Given this list of marker genes G6PC3, NUTF2, USP8, LAPTM4B, ITPR1, DPAGT1, CRIP1, IAH1, EXTL3, OAT, MAGOHB, GKAP1, TMBIM1 (NCBI Gene Id 64114), MACIR, TAX1BP3, PPP2R3C, C18orf54, RCAN1, DPY19L4, ZC3H12C, IFT52, SUPT3H, HMGA1, IQGAP3, RAB11A (NCBI Gene Id 8766), PRELID3B, TUBB2A, CENPE, TOR3A, DBI, AVPI1, AKT1, BRIP1, ARHGDIA, SLC25A11, ARHGAP26, TMEM107, PGLS (6-phosphogluconolactonase), PGAP6, HK3, VAMP8, VPS35, DNAJB14, B4GALT4 (NCBI Gene Id 8702), PREP, CTNNBIP1, ANP32E, SUMF1 (sulfatase modifying factor 1), GNB2, IMPA2, QSER1, NAGPA, KPNA3, LANCL2, COP1, SLC25A24, RNF130, DOCK7, GCA, LSR, MAP4K1, NIPA2, MAP2K4, MCUB, CD38, BCL2L14, MAPKAPK2, CTDNEP1, SLC25A39, SOCS5, RANBP1, NFKB2, LTBR, SNX10 (sorting nexin 10), HPSE (NCBI Gene Id 10855), WDR11, TUFT1, MOB1A, E2F1, MOB3B, CCNA2, ELOA, PTPN9, LPCAT1, BID, WDR41, CBR3, SPAG9, DLGAP5, DUT, KIF5A, STT3A, ANXA7, SIGMAR1, FCER1G, NEDD8, EVI2B, GAS2L3, HINT1, ILDR1, RNF135, NCKAP1L, IFNAR2, MX2, MFSD12, TLR2, ATP6V0E1, MMS22L, TGFB1, SEPSECS, PLEKHO2, CSGALNACT2, PMF1, ELMO2, PALLD, ATAD2, LAP3, SNRPD1 (NCBI Gene Id 6632), CCDC28B, TSPAN31, RRAGC, SLC35E3, MED9, XBP1, DCLRE1A, MIS18BP1, CAPZA2, DEK, PLK4, CDC45, RCN2, SSR3, MTHFS, CALR, NRM, CYB5R4, LITAF, HIPK2, C4orf19, SERPINB9 (NCBI Gene Id 5272), UGGT1, AURKA, EID1, MTCH1, UMAD1, PLEKHG3, IL13RA1, SKP2, RPS27L, MYO18A, KIF23, SH3BGRL3, DSN1, TMTC3, UBE2E3, CCDC88A, NDST2, SOX12, KIFAP3, MAN1C1, FANCL (NCBI Gene Id 55120), NDC1, TEP1, SH2B3, STX12, TAOK2, TMED3, LIX1L, SNRPA1, CENPS, FNBP1L, MATK, RCC1 (NCBI Gene Id 751867), G3BP1, IL4I1, CASP7, ALMS1, PNPO, YWHAG, TM2D2, GAMT, SEMA4C, NOTCH2, TRIT1, PPT2, AKAP1, GLCE, PDIA3, EEFSEC, RFC4, SLC25A4, PALB2, GCNT1, PSEN1, IPO5, ALS2, POLR1H, CENPI, M6PR, MST1, here is a description of the gene set: species: Homo sapiens from publication Suryani S, Fulcher DA, Santner-Nanan B, Nanan R, Wong M, Shaw PJ, Gibson J, Williams A, Tangye SG (PMID 19965666) Human Gene Set: GSE17186_BLOOD_VS_CORD_BLOOD_CD21HIGH_TRANSITIONAL_BCELL_UP Genes up-regulated in transitional CR2 high B lymphocytes versus those from cord blood. Goals/objectives: to identify various gene expression in B cell subsets derived from human PBMC and cord blood